The following is a description of a gene set: Glyoxylate metabolism and glycine degradation Human Gene Set: REACTOME_GLYOXYLATE_METABOLISM_AND_GLYCINE_DEGRADATION studied in species Homo sapiens, and this is the list of marker genes: GOT2, DLD, HAO1, AMT, AGXT, GNMT, DDO, GLDC, KGD4, GCSH, ALDH4A1, GRHPR, PRODH2, HOGA1, PXMP2, DAO, OGDH, AGXT2, DLST